Given this list of marker genes CCL2, PRKCA, PRKCD, TRAF2, TREM2, RAD21, PRKCH, DLL1, PRKCI, GAS6, here is a description of the gene set: Any process that stops, prevents, or reduces the frequency, rate, or extent of glial cell apoptotic process. Human Gene Set: GOBP_NEGATIVE_REGULATION_OF_GLIAL_CELL_APOPTOTIC_PROCESS studied in species Homo sapiens